Given this list of marker genes Htr2c, Slc27a1, Nr1h4, Chp1, Capn2, Adgrf5, Acsl3 (NCBI Gene Id 96921, acyl-CoA synthetase long-chain family member 3), Erbb4 (erb-b2 receptor tyrosine kinase 4), Abca2, Lpcat1, Htr2b, Pdgfb, Fabp3, Pdgfa, Bscl2, Scp2, Pcx, Rab38, Htr2a, Idh1, here is a description of the gene set: Mouse Gene Set: GOBP_REGULATION_OF_PHOSPHOLIPID_BIOSYNTHETIC_PROCESS species: Mus musculus Any process that modulates the frequency, rate or extent of the chemical reactions and pathways resulting in the formation of phospholipids.